Given this list of marker genes NARF, LMNB1, LMNTD2, LMNA, EIF6, here is a description of the gene set: Human Gene Set: GOCC_LAMIN_FILAMENT Any of a group of intermediate-filament proteins that form the fibrous matrix on the inner surface of the nuclear envelope. They are classified as lamins A, B and C. studied in species Homo sapiens